Given this list of marker genes CORO1A, PNPT1, RBCK1, SNRNP70, PRKD2, PIGR, CD27, HLA-G, FCGR1A, IRF9, DAPP1, LILRB1, STAT1, STAT2, LILRB3, TAPBP, ISG15, TNFSF14, CSF2RA, here is a description of the gene set: BACKGROUND: Annual vaccination is the primary means for preventing influenza. However, great interindividual variability exists in vaccine responses, the cellular events that take place in vivo after vaccination are poorly understood, and appropriate biomarkers for vaccine responsiveness have not been developed. METHODS: We immunized a cohort of healthy male adults with a licensed trivalent influenza vaccine and performed a timed assessment of global gene expression before and after vaccination. We analyzed the relationship between gene expression patterns and the humoral immune response to vaccination. RESULTS: Marked up regulation of expression of genes involved in interferon signaling, positive IL-6 regulation, and antigen processing and presentation, were detected within 24 hours of immunization. The late vaccine response showed a transcriptional pattern suggestive of increased protein biosynthesis and cellular proliferation. Integrative analyses revealed a 494-gene expression signature--including STAT1, CD74, and E2F2--which strongly correlates with the magnitude of the antibody response. High vaccine responder status correlates with increased early expression of interferon signaling and antigen processing and presentation genes. CONCLUSIONS: The results highlight the role of a systems biology approach in understanding the molecular events that take place in vivo after influenza vaccination and in the development of better predictors of vaccine responsiveness. from publication Bucasas KL, Franco LM, Shaw CA, Bray MS, Wells JM, Niño D, Arden N, Quarles JM, Couch RB, Belmont JW (PMID 21357945) species: Homo sapiens Genes positively correlated with a functional network in peripheral blood mononuclear cell in Caucasian male adults (18-40) (high responders) after exposure to Fluarix/Fluvirin, time point 1D. Comment: Top functional network for genes preferentially upregulated in the high responder group Human Gene Set: BUCASAS_PBMC_FLUARIX_FLUVIRIN_CAUCASIAN_MALE_AGE_18_40YO_HIGH_RESPONDERS_1DY_TOP_FUNCTIONAL_NETWORK_POSITIVE